The following is a description of a gene set: part of: DDX58/IFIH1-mediated induction of interferon-alpha/beta Reactome Pathway: TRAF3-dependent IRF activation pathway studied in species Mus musculus This event has been computationally inferred from an event that has been demonstrated in another species.<p>The inference is based on the homology mapping from PANTHER. Briefly, reactions for which all involved PhysicalEntities (in input, output and catalyst) have a mapped orthologue/paralogue (for complexes at least 75% of components must have a mapping) are inferred to the other species. electronically inferred by orthology from the curated human pathway, and this is the list of marker genes: Irf3, Irf7